Given this list of marker genes BABAM1, MORC1, SERF2, FOXK2 (forkhead box K2), UBE4A, COG1, MRM2, TMEM219, SIDT2, MRPS23, MCM7, SURF1, WAS, CYB5R3, BCL11B, DCLRE1B, HMOX2, LYPLA2, MTFR2, FASN, KRBA1, ARMC5, SEMA5B (semaphorin 5B), RUFY3, RPLP1, SCAF11, FERMT3, TOM1, NDUFB8, DIAPH1, EIF2B2, CENPE, IGFBP4, PBX1, CNPPD1, CDIPT, ID3, ARL4C, SOX21, PCSK2, STK10, PABIR1, RPL18, NOMO1, COPS8, TRIM10, MRPL22, MFNG, UROD, DDA1, MLX (MAX dimerization protein MLX), DGCR2, NAB2, CYTH1, GTF2A1, NOP58, SLCO3A1, DAXX, ILRUN, TMEM119, QNG1, RPL36, PI4KA, CCNF, HELZ, NSMCE1, AP4S1, ATP5MF, CTU1, LDHB, COX6A1, NOTCH1, CYP2S1, CYFIP2, SELENOW (selenoprotein W), NIF3L1, GADD45A, PDCD2, FYN, DDX21, PRDX5, GPATCH1, MACROD1, RASSF5, DEAF1 (NCBI Gene Id 105376508), POLR3E, SLC7A10 (NCBI Gene Id 83251), FAM20B, TMPRSS4, CLDN5, WDR5, DENND1A, NDUFA11, PPM1G, SNRPC, FBXW4, PHC1, NDUFV3, ALDH9A1, AKR7A2, PHPT1, SH3BGRL3, CUX1, OGDH, ZFPM1, BAP1, MMACHC, COQ5, PLCD1, TPM3, GNAI2, CHST12, DDOST, TIMP2, ITM2A, APRT, NDUFB7, IMPDH2, MRRF, NAA80, RCBTB2, SETD4, PLSCR3, SIN3B, RPS16 (NCBI Gene Id 6217), ELOVL1, PRPF40A, HACE1, S1PR4, RALA, MCRIP1, RPL28, PCNX1, GRAP2, VPS39, SLC47A1, ECE2, KCND2, ENPP4, CTCF, BPHL, CHRNA1, ASB14, TMEM42, LIMD2, TMEM160, ZNF526, GRWD1, GPATCH4, EMP3, NCAM2, ARMCX5, HPS4, TAF10, SAMM50, DERA, CDC25A, CITED4, ELF5, TXN2 (thioredoxin 2), SSRP1, TMEM43, CCT2, PIGQ, TUBA4A, BPIFA2, SHMT2, MED22, ACSS2, AARS1, CLTB, RASGRP2, ANXA13, TBL2, MYO6, RBX1, G0S2, CBR1, SLC25A35, UCK1, TOX4, COQ4, IER2, PIP5K1C, TDRP, TMEM229B, GABPB1, ARPP19, PPIF, SLC2A2, PITX2, ARID2, ASRGL1, FOXP1, C11orf68 (NCBI Gene Id 83638), PRKCQ, UBR7, RPL7L1, MYO5B, TFPT, here is a description of the gene set: Human Gene Set: GSE16266_CTRL_VS_HEATSHOCK_AND_LPS_STIM_MEF_DN from publication Takii R, Inouye S, Fujimoto M, Nakamura T, Shinkawa T, Prakasam R, Tan K, Hayashida N, Ichikawa H, Hai T, Nakai A (PMID 20018623) species: Homo sapiens To clarify inflammatory genes whose expression is suppressed at high temperatures, we performed comprehensive analysis of gene expression by using a DNA microarray. Two independent primary cultures of mouse embryo fibroblasts (MEF1 and MEF2) were treated with LPS for 4 hours, or treated with LPS for 4 hours after the pretreatment with heat shock at 42˚C for 1 hour, and we identified genes that undergo more than a 3-fold increase with LPS treatment. Remarkably, genes (86%) underwent less than a 2-fold increase after combined treatments with heat shock and LPS in MEF1 and MEF2 cells. Genes down-regulated inmouse embryonic fibroblasts (MEF): control versus LPS and heat shock.